The following is a description of a gene set: Human Gene Set: REACTOME_STIMULI_SENSING_CHANNELS Stimuli-sensing channels species: Homo sapiens, and this is the list of marker genes: TRPC1, SGK3, TRPC7, ASIC5, UNC80, WNK2, ASIC1, ASIC3, TTYH1, ANO4, TRPC4AP (transient receptor potential cation channel subfamily C member 4 associated protein), SLC9C2, CLCN5, CALM1, TRPC6, RYR3, TTYH3, CASQ2, BEST3, TRPC3, SRI, NALCN, ASIC4, CLCNKB, CLCN2, CLCN7, TRPM2, TRPV3, UBB, CLIC2, TRPM6 (transient receptor potential cation channel subfamily M member 6), SCNN1G, TRPM5, SCNN1A, TRPV2, TRPA1, ANO7, RYR2, SLC9C1, CLCN6, OSTM1, ANO3, STOML3, UBC, UBA52, CLCN4 (chloride voltage-gated channel 4), TRPV1, NEDD4L, CLCN1, ANO5, WNK4, FKBP1B, TRPM3, SCNN1D, ANO2, TRPM1, WNK3, TRDN, TRPC5, CLCN3, BEST2, CLCA4, MCOLN1, TRPM7, TRPM4 (NCBI Gene Id 8184), RYR1, CASQ1, ANO10, WNK1, TRPC4, TPCN1, ANO1, TTYH2, RAF1, TPCN2, CLCA2, MLKL, CLCNKA, SLC17A3, CLCA1, BSND, WWP1, MCOLN3 (NCBI Gene Id 55283), TRPV6, ANO6, SCNN1B, STOM, TSC22D3, RPS27A, SLC9B1, TRPM8, SGK1, ASPH, TRPV4, SLC9B2, BEST1, ANO8, ASIC2, SGK2, RIPK3, BEST4, RIPK1, ANO9, MCOLN2 (mucolipin TRP cation channel 2, NCBI Gene Id 255231), UNC79, TRPV5